The following is a description of a gene set: Human Gene Set: MODULE_136 species: Homo sapiens Genes in the cancer module 136., and this is the list of marker genes: PNMA8A, PTPRT, CLEC2B, KATNIP, ZBTB5, UNC79, F3, SURF6, SCD, MAP6D1, ZNF292, NFIL3, GOLGA5, TMEM144, ANKRD13A, SPNS1, PTPRZ1, NOP56, SMG7, MCMBP, LY86 (lymphocyte antigen 86), MXRA8 (NCBI Gene Id 84308), SYCP2, MAPK4, TMEM121B, DNAAF4, GOLGA4, YWHAB, KIAA2013, DHODH, ATG4D, TMED3, ACSBG1, ZNF264, RPRM, IFI27, NUP58, NHSL3, TNFRSF13C, KLF13, SH3BP2, CD9, PLAAT4, DCANP1, ELMO1, TNFSF4, REV3L, HNRNPU, IWS1, ATRN, SENP1, PPP1CB (protein phosphatase 1 catalytic subunit beta), CHL1, CTSZ, SLC17A8, SLX4, CDH22, FAF1, CHST9, PTX3, CCNG1, FOS, PPIL2, ERMN, VAV1, PPP4R2, PCSK5, CDH4, DZIP3 (NCBI Gene Id 9666), BCL2L13, ATP8A2, KLHL4, ART3, CPNE1, TP53, MAP4, HNRNPDL, POGLUT2, ECEL1, ALDOA, DHRS12, ILRUN, PIP4K2C, BSDC1, IMMT, HYAL2, ITGA4, CCDC81, CCDC85C, ISYNA1, IL1RL1, SNRNP25, BARD1, CLCF1, UFSP2, CDK11A, ERVMER34-1, ELAC1, SMAD3, FAR2, RNF220, FBXW4, SLC11A2, GEMIN7, SOX1, C19orf73, NACAD, DPH5, OBSCN, MRPL18, FBXO11, GRAPL-AS1, ALDH1B1, SNX5, PARS2, EDN1, LANCL2, GLT8D1, SV2B, MICALL1, COCH, RFX7, MMP7, FURIN, SFT2D3, PYCR3, BPIFA1, MED12L, GPR68, MYEF2, DIAPH2 (diaphanous related formin 2), ATG2A, ZNF143, CCDC90B, CHD1, PITPNC1 (phosphatidylinositol transfer protein cytoplasmic 1), LMO7, P4HTM, CEP55, ZCCHC4, ELOVL2, PNPLA2 (patatin like phospholipase domain containing 2), SF3A1, RXRA, TRUB1, SOX6, ARID5A, ACVR1, TRIM48, ESPN, PRPF39, NCOA7, COQ8A (coenzyme Q8A), ASXL2, DIRAS2, GSTZ1, HACD1, USP36, SLC9A6, CYP1A1, EPCIP, MREG, DDX17, IFT80, CCNH, MPRIP, TMEM161A, ZNF318, CD8A, LDAH (NCBI Gene Id 60526), PDCD5, APTX, NUTM2F, CACNA2D3, ACKR1, SLAMF7, HBE1, SLC43A1, MYL12A, MAP1S (microtubule associated protein 1S), TUBA4A, CEBPZ (CCAAT enhancer binding protein zeta), AMOTL2, THUMPD1, STRIP2, ENPP1, RALGPS2, SH2B3, FAM220A (NCBI Gene Id 84792), ZNF107, ATG16L1, UGCG, ZGRF1, BRAP, CELF2, FABP2, SLC26A8, CDK16, TRIM7, COL6A3, NRL, DNAJA1P5 (NCBI Gene Id 94236), IL1A, PCGF1, BPTF, ALG6, HIVEP2, MMP14, SIPA1L3, PHF3, SP140L, CENPK, REPIN1, UBE2J1 (ubiquitin conjugating enzyme E2 J1), BFSP2-AS1, TRIM14, CEP162, SCARA3, MYH1, SLMAP, LINC00160, KIF18A, SPAG9, TIMP4, AKAP8L, DNAJC12, CCDC134 (coiled-coil domain containing 134), CSF1, ABHD17C, S100A5, MCTS1, PAWR, AURKAIP1, OSBPL9, RRAGD, CIP2A, MTMR12, PIF1, UNKL, PROM1, AGAP2, EARS2, CMTM6, CUL9, CST1, RNF103, C17orf75, NEPRO, PDCD2L, BEGAIN, ZNF117, MRPL27, GPSM3, UTP11, ITK, BCR, MYBL2, GSTM1, VIT, RARB, SSBP4, TMCC2, RNASEL, ZBTB7A, TRABD, NECAP2, TMEM120A, QSER1, ISCU, IL18R1, MOB4, KAT2B, OR2A1, GPATCH3, ZMYM5 (zinc finger MYM-type containing 5), KRT19, PDE4D, MRPL36, COPE, RERE, GREB1, SLC19A1, MED25, RABGAP1, HOXC4, TLN1, PLEKHF2, TIMELESS, SOX21, PLEKHG1, NXF1 (nuclear RNA export factor 1), MBD5, PRDM8, RBAK, CCNL1, WRNIP1, TM9SF3, GJA1, NOP53, TMLHE, CYP2A7, FGD6, SARAF, SELP, ZMYM6, SLITRK1, TYMP, LY9, AMIGO1, ZNF202, CORIN, GABPB1-IT1, OXGR1, TAL1, NME1, PCED1B, ACTR6 (NCBI Gene Id 64431), FPR2, DEGS1, CDH5, SIN3A, MICB, RBM7, DCLK1, TMEM62, MLYCD, LRRC4C, HS1BP3, KDM4D, CAAP1, ACSM5 (acyl-CoA synthetase medium chain family member 5), TRMT6, CHST1, LHPP, WSB2, ABI3, ADIPOR2, PGLYRP2, POU6F2, MRPS15, BCL2L14, SDC3, HMGN5, AASS, CXCL8, ANKRD1 (ankyrin repeat domain 1), INO80B, EYA3 (EYA transcriptional coactivator and phosphatase 3), NGF, TBC1D9, NELFB, ARHGAP15, MST1R, DEXI, MTTP, PAPOLA, SLC25A27 (NCBI Gene Id 9481), FLJ13224, FMN1, DYNC2LI1, C1orf116, MED14, BAIAP3, WDR46, RFC2, SPMAP2 (NCBI Gene Id 91957), IGKC, EPS15L1, PDCD6, NEIL1, GJC2, ELSPBP1 (epididymal sperm binding protein 1), NANS, ARHGAP45, LYL1, CDH23, IL1R2, PHAX, KLHL41, ZNF566, LEPROTL1, CAPRIN1, NMT1, MAPKBP1, PYGB, PTPRF, CLUH, LRP3, ZNF638, GALNT3, METTL22, SAV1, BTN2A1, GSTM4, ITGAM, MAGEL2, NOL7, CAND1, NR2E1, INIP, CITED2, GJA5, ATXN7, EIF2B4, PORCN, SUGP2, EPHA7, LMTK3, KLHL36, CELP, DDX60, ZFP41, ITM2C, NSUN3, CCAR2, HSD17B12, EGFR, DCTN3, ZKSCAN7, GATA3, CYP2B7P, ERLIN2, BRIP1, XPO4, CD1A, ELOB, FOSL2 (FOS like 2, AP-1 transcription factor subunit), IPCEF1, NXPH4, TESPA1, MAGED4B, GEMIN4, PKIA, PTGS2, KDM5B, MOCOS, TMEM97 (transmembrane protein 97), CYYR1, DDX11, USP30, XRN2, OTOR, LRRC19, OR7E12P, MRPL47, TBC1D8B, WDR19, TMEM250, PPP1R14D, MSX1 (msh homeobox 1), DES, STRN, TTF2, PRDM1, TSLP, POLDIP3, LARP1, AMZ2, NUP54, TDP1, STAT3, SLC22A3, RHPN1, BHMT2, STAMBPL1, CCBE1, BAG3 (BAG cochaperone 3), ITGB5, PI4K2B, KCNE4 (NCBI Gene Id 23704), ZMAT4, FNBP4, PLEKHM2, EEF1D, TNFRSF17, EFCC1, TMEM248, TOR4A, BASP1, CNKSR2, CHD9, SIAH1, MORC3, GLB1L, CD1D, KATNAL1, QKI, PLGLB2, PLIN1, DPYD, WDR25, DIO3